The following is a description of a gene set: Pathway Definition from KEGG: (IL6,IL11,IL13,IL27,IL31,OSM,LIF,CNTF,CTF1,CLCF1) -> ((IL6ST+(IL6R,IL11RA,IL27RA,OSMR,LIFR,CNTFR)),(IL4R+IL13RA),(IL31RA+OSMR)) -> (JAK1+JAK2+TYK2) -> (STAT1,STAT3,STAT6) IL6 family to Jak-STAT signaling pathway. Pathway ID: N01556. Pathway type: Reference. Pathway class: nt06518 JAK-STAT signaling. Human Gene Set: KEGG_MEDICUS_REFERENCE_IL6_FAMILY_TO_JAK_STAT_SIGNALING_PATHWAY studied in species Homo sapiens, and this is the list of marker genes: IL11, IL13RA2, IL6, IL11RA, CNTF, IL6R, IL31RA, JAK1, IL4R, LIF, TYK2, LIFR, IL27RA, CLCF1, STAT6, OSMR, IL27, CNTFR, CTF1, JAK2, IL6ST, STAT1, IL13, STAT3, IL31, IL13RA1, OSM